Given this list of marker genes GCSH, ZCCHC4, WIF1, RABEP1, ZFC3H1, CSF2RA, MSR1, ZCCHC17, UBA5, RPS25, SLC35A4, TMEM42, HPS3, DHPS, FXYD5, SMIM7, PWWP2A, CYBA, SLC12A6, MARF1, NTAQ1, DENND1B, ATP6V1D, ATOSA, FAM98C, TRAPPC8, MAPK11, RBM28, TRIM35, ICE2, YIF1A, PIGP, ETFB, IMMT, MRPL24, GLUD1, NOL11, FAM91A1, TASOR, IVNS1ABP, ARFGAP2, TUFM, GAN, TAF1B, CD2AP, MECR, GLS, CYB5R1, HM13, DARS2, RABAC1, USE1, SSNA1, C12orf57, SNAPC4, RADIL, TUFT1, WASHC2A, CLK4, HIGD2A, CLEC7A, LAMTOR4, MESD, SCAMP2, GORAB, ORC4, ABHD12, FRMD4B, B3GNT5, XBP1, CAMKMT, KMT5B, BCL2L13, DTYMK, QDPR, ACAT1, EXO5, RPS26, TRMT10B, SMIM11, TBC1D23, DNAJC10, TTC33, EXOC5, POLK, MIA3, KDM3A (NCBI Gene Id 55818), ATXN1L, ZMYM2, BAZ2B, LPGAT1, CUL2, ZRANB2, SLMAP, KLF3, YTHDC1, SENP5, SERP1, CRCP (NCBI Gene Id 27297), ZNF280D, PRDM1, ZBTB33, JADE3, MTLN, LTV1, TSG101, ASH1L, NAA30, ATAD1, GDPGP1, NAB1, RLF, TMEM185A, MYO5A, POGLUT1, SLC9A9, ACO2, CCDC86, TPRA1, MTERF3, RNF215, NFRKB, CWF19L2, TCEANC2, TERF1, TWF1, OSBPL9, USP24, CC2D1B, REV1, SOS2, TMEM18, SUN2, RCHY1, PSENEN, ITGB2, DHX57, RALGPS2, PDK1, TTN, MFSD8, TRMT11, TMEM43, ASPSCR1, OLFM1, ELAC1, POU2AF1, CX3CR1 (C-X3-C motif chemokine receptor 1), RPP25, CABLES2, HAPSTR1, SLC7A6, FAM204A, MFSD9, ANTKMT, DCLRE1C, NCBP3, DNAJA2 (DnaJ heat shock protein family (Hsp40) member A2), TFRC, D2HGDH, RBM18, BMPER, HLA-DRB1, MRPL32, PRMT9, TTPAL, CABP2, CLEC12B, ACD, SLC25A45, C9orf78, PLCG1, PIBF1, SNX9, MRPS34, CPEB2, SORT1, BBS10, PIGL (NCBI Gene Id 9487), CD209 (NCBI Gene Id 30835), IREB2, TFB2M, APPL2, ZNF296, PTBP2, C19orf48P, FYTTD1, ZNF688, ZNF318, CCNL1, TMEM86B, ITGB3BP, CCNT2, TMEM35B, TMED8, PDHA1, KANK3, TTLL3, FBXL6, ARL6IP6, here is a description of the gene set: Human Gene Set: GSE2770_UNTREATED_VS_TGFB_AND_IL12_TREATED_ACT_CD4_TCELL_6H_UP Genes up-regulated in CD4 T cells: untreated (0h) versus activated by anti-CD3 and anti-CD28 and then stimulated by TGFB1 and IL-12 (6h). species: Homo sapiens Th1 and Th2 cells arise from a common precursor cell in response to triggering through the TCR and cytokine receptors for IL-12 or IL-4. This leads to activation of complex signaling pathways, which are not known in detail. Disturbances in the balance between type 1 and type 2 responses can lead to certain immune-mediated diseases. Thus, it is important to understand how Th1 and Th2 cells are generated. To clarify the mechanisms as to how IL-12 and IL-4 induce Th1 and Th2 differentiation and how TGF-beta can inhibit this process, we have used oligonucleotide arrays to examine the early polarization of Th1 and Th2 cells in the presence and absence of TGF-beta after 0, 2, 6 and 48 hours of polarization. from publication Lund R, Aittokallio T, Nevalainen O, Lahesmaa R (PMID 14607935)